Given this list of marker genes CCL5, CCL11, TNFAIP3, VCAM1, TNF, THBS1, IL10, LTA, VNN1, ADORA2B, CEBPB, CYP19A1, UNC13D, S100A9, CAMP, IDO1, S100A8, CXCL13, FOXP3, NFKBIZ (NCBI Gene Id 64332), SCN11A, here is a description of the gene set: Human Gene Set: GOBP_CHRONIC_INFLAMMATORY_RESPONSE species: Homo sapiens Inflammation of prolonged duration (weeks or months) in which active inflammation, tissue destruction, and attempts at repair are proceeding simultaneously. Although it may follow acute inflammation, chronic inflammation frequently begins insidiously, as a low-grade, smoldering, often asymptomatic response.